Given this list of marker genes CDK2 (NCBI Gene Id 1017), RIPOR2, SVIP, TFDP2, GSG1, KNSTRN, CDCA2, CARS2, PIK3R2, RFC2, NNT, IRF4, FGD2, NFATC2, DDB2, PPARGC1B, CORO1A, CCNE2, STARD7, DDX39B (DExD-box helicase 39B), WDR7, RINL, PTPN18, CENPF (centromere protein F), PSME2, GCC2, OGFRL1, GALNT11, OGT, TRIM28 (NCBI Gene Id 96054), RASGEF1B, AKR1E2, GEMIN4, TNFRSF13B, MRPL58, ARMC6, C19orf48P, CYP1B1, JMJD8, SMARCC1, TIFA, CDPF1, VAMP5, NEURL1B, DCAF4, MB21D2, RAB39A, SLC35A1, COQ9, RTN4RL1, TUBB, DEPTOR, POLR2E, IGDCC4, PYCR2, P2RY13, CCDC106, ENPP4, PHETA1 (PH domain containing endocytic trafficking adaptor 1), PRKRA, TMEM14A, CRACDL, RASGRP2, MPPE1, CRBN, RCSD1, GATB, RPA3, RFX7, CAND2 (NCBI Gene Id 23066), MAT2A, SLC6A13, NME7, TAF6, IPO9, CEBPA, FBXO25, SSBP3, SHTN1, CELF2, LIFR, OXCT1, AGO1, TMEM119, FRRS1, NAGK, FES, SLA2, AGBL3, ENDOG, RIOX2, PIGX, ADI1, CHD1L, RASGRP4, TRAPPC10, C4orf46, FGR, DAB2IP, CPT1A, FKBP15, AURKB, DIPK1A, PRPS1, EEF2K, PEPD, FAM217B, NUDT19, USP46, EZH2, PELP1, PAFAH1B3, KIZ, DSCC1, ATM, FAM234B, TMEM86A, XXYLT1, HCFC1, KIF20B, CKS1B, PARP8, KIF23, GMNN, ENTPD4, TMEM80, ADORA3, TMEM39B, IGHM, PSTK, RNF220, NISCH, ANGPTL4 (NCBI Gene Id 93954), SFXN1, GTF2I, PSMB8, INPP5B, MRPL2, TRIM14, PDLIM2, TRAF3IP3, FAM185A, B4GALNT4, TMEM164, GSDMD, MCRIP2, NRP1, CCND3, ID1, MEGF8, WDR11, MYB, TOX, MTARC2, MEIS2, RCC2, HAGHL, LRRK1 (NCBI Gene Id 79705), CDT1, NMI, HEATR5B, TRIM37, CEP41, ACSL5, PRKD3, DNAJC12, MAP3K4, APEH, PRSS16, HDDC3, SNX7, RCC1L, ZNRD2, SLC25A11, GPR183, EIF2AK2, DUSP6, TBC1D2B, TTLL12, SORL1, MTFR2, MVB12A, RRP1B, LHPP, MMUT (NCBI Gene Id 4594), MRPL4, SCCPDH, C8orf82, UNG, KLHL6, NUDT22, MAP4K1, SRR, LRWD1, PNPO, UQCC3, CCAR2, DPY30, SLC12A5, PGAM5, here is a description of the gene set: Genes down-regulated macrophages with MYD88 knockout: untreated versus 12h after M. bovis BCG infection. from publication Qualls JE, Neale G, Smith AM, Koo MS, DeFreitas AA, Zhang H, Kaplan G, Watowich SS, Murray PJ (PMID 20716764) Nitric oxide (NO) produced by macrophages (MØs) is toxic to both host tissues and invading pathogens and its regulation is therefore essential to suppress host cytotoxicity. MØ arginase 1 (Arg1) inhibits NO production by competing with NO synthases for arginine, the common substrate of NO synthases and arginases. Two signal transduction pathways control Arg1 expression in MØs. First, a MyD88-dependent pathway induces Arg1 in intracellular infections, while a second Stat6-dependent pathway is required for Arg1 expression in alternativelyactivated MØs. We found that mycobacteria-infected MØs produce soluble factors that induce Arg1 in an autocrine-paracrine manner via Stat3. We identify these factors as IL-6, IL-10 and GCSF. We further establish that Arg1 expression is controlled by the MyD88-dependent production of IL-6, IL-10 and G-CSF rather than cell intrinsic MyD88 signaling to Arg1. Our data reveal the MyD88-dependent pathway of Arg1induction following BCG infection requires Stat3 activation and may result in the development of an immunosuppressive niche in granulomas due to the induced Arg1 production in surrounding uninfected MØs studied in species Homo sapiens Human Gene Set: GSE22935_UNSTIM_VS_12H_MBOVIS_BCG_STIM_MYD88_KO_MACROPHAGE_DN